The following is a description of a gene set: studied in species Mus musculus Mouse Gene Set: TABULA_MURIS_SENIS_HEART_VENTRICULAR_MYOCYTE_AGEING from publication Tabula Muris Consortium (PMID 32669714), and this is the list of marker genes: Eif3b, Klc1, Cpe, Actn2, Cpt1b (NCBI Gene Id 12895), App (amyloid beta precursor protein), Plp1, Puf60, Kcnk3, Trim63, Got2, Clu, Fcrl2, Nectin2, H2-D1, Psap, Pcbp1, Dnaja4, Map7d1, Pbxip1, Btbd1, Mtus2, Hnrnpab, Esrra, Maea, Laptm4a, Kcng2, Lrp10, Tppp3, Aldh2, Amfr, Serinc1, Sec23ip, Laptm5, Gaa (glucosidase, alpha, acid), Tubb4b, Rraga, Arl6ip5, Psmd1, Unc45b, Vcp, Dmpk, Rnf10, Tpm2, Eef1a1, Ric8a, H2-K1, Lamp1, Copb2, Spr, Trim54, Prpf19, Atp1a1, Psmd13, Nppa, Smtn, Bckdha, Eef2, Maged1, Aldh1b1, Cct3, Ctbp1, Sqstm1, Gpx3, Hspb7, Slco3a1, Slc20a2, Rrp1, Copa, Lamb2, Atp6ap1, Fkbp8, Csnk1g2, Cap2, Dkk3, Kdelr1, Uba1, Bcam, Doc2g, Adss1, Ptov1, Calcoco1, Emd, Selenbp1, Chrm2, Tmed9, Trf, Thrap3, Cd151, Ces1d, G3bp1 (G3BP stress granule assembly factor 1), Oat, Ahsg, Tle5, Emc10, Jund, Ehd4, Raly, Dctn1, Ewsr1, Gnas, H1f0 (H1.0 linker histone), Gatd3a (NCBI Gene Id 28295), Selenot, Clip4, Psmd3, Pink1, Map2k2, Corin, Med25, Pam (NCBI Gene Id 227401), Lmna, Nudt4, Sox4, Pkm